The following is a description of a gene set: from publication Chen Y, Wang X (PMID 31504780) species: Mus musculus Mouse Gene Set: MIR_674_3P Genes predicted to be targets of miRBase v22 microRNA mmu_miR_674_3p in miRDB v6.0 with MirTarget v4 prediction scores > 80 (high confidence targets)., and this is the list of marker genes: Eif4enif1, Mmp16, Ythdf1, Rasgef1b, Rlig1, Cfap74, Vdac2, Pck1, Parvb, Rasgef1a, Atp8b2, Ptbp1, Vps54, Rpgrip1l, Klhdc3, Mbtps2, Grhl2, Corin, H2-M10.3, Ddx6, Marchf5, Cdkn2aip, Ago1, Scg2, Mob4, Tiam2, Cxxc4, Larp4b, Slc17a5, Afdn, Zc4h2, Wdr6 (NCBI Gene Id 83669), Dnajc19, Tm9sf3, Mrpl49, Trps1, Zranb2, Ttll11, Zfp354a, Rtf1, Pter, Cds2, Vapb, Acer3, Grip2, Pnisr (NCBI Gene Id 66625), B3galnt2, Ltbp1, Cebpzos, Med27, Clcn3, Casr, Gpam, H2bw2, Dlg3, Ube2j1, Rnase4, Gcsam, Abhd10, Eloc, Kif3a, Neu3, Gopc, Crebrf, Lgr4, Tut4, Gpr183, Tbc1d23, Bend4, St8sia4, Fra10ac1, Fam118b, Ing3, Bpnt2, Spire1, Igfbp6, Cdh2, Cuedc1, Rcn1, Dhx36, Proser2, Nr3c1, Kmt2c